Given this list of marker genes Ghitm, Afg3l2, Hspa9, Micu2, Bhlha15, Smdt1, Letm2, Mcu, Micu3, Spg7, Opa1, Akt1, Mcur1, Maip1, Mcub, Itpr1 (inositol 1,4,5-trisphosphate receptor 1), Micu1, Ucp2, Letm1, Selenon, Slc8b1, Slc8a3, Psen2 (NCBI Gene Id 98295), Slc25a23, Vdac1, here is a description of the gene set: Mouse Gene Set: GOBP_MITOCHONDRIAL_CALCIUM_ION_TRANSMEMBRANE_TRANSPORT The process in which a calcium ion (Ca2+) is transported across a mitochondrial membrane, into or out of the mitochondrion. studied in species Mus musculus